The following is a description of a gene set: Mouse Gene Set: CUI_NK_CELL_IL5_RESPONSE_UP Genes positively differentially expressed in cell type: NK cell upon treatment with cytokine: IL-5 in mouse lymph nodes in vivo. species: Mus musculus Cytokines mediate cell-cell communication in the immune system and represent important therapeutic targets. A myriad of studies have highlighted their central role in immune function, yet we lack a global view of the cellular responses of each immune cell type to each cytokine. To address this gap, the authors created the Immune Dictionary, a compendium of single-cell transcriptomic profiles of more than 17 immune cell types in response to each of 86 cytokines (>1,400 cytokine-cell type combinations) in mouse lymph nodes in vivo. A cytokine-centric view of the dictionary revealed that most cytokines induce highly cell-type-specific responses. For example, the inflammatory cytokine interleukin-1β induces distinct gene programmes in almost every cell type. A cell-type-centric view of the dictionary identified more than 66 cytokine-driven cellular polarization states across immune cell types, including previously uncharacterized states such as an interleukin-18-induced polyfunctional natural killer cell state. from publication Cui A, Huang T, Li S, Ma A, Pérez JL, Sander C, Keskin DB, Wu CJ, Fraenkel E, Hacohen N (PMID 38057668), and this is the list of marker genes: Lbh, Pfn1, Ndufs8, Tubb4b, Proser1, Nudcd2, Cycs (cytochrome c, somatic), Erh, Slc30a5, Mettl1 (methyltransferase 1, tRNA methylguanosine), Mcu, Guk1, Gngt2, Fam162a